The following is a description of a gene set: from publication Chen Y, Wang X (PMID 31504780) Genes predicted to be targets of miRBase v22 microRNA hsa-miR-6762-3p in miRDB v6.0 with MirTarget v4 prediction scores > 80 (high confidence targets). Human Gene Set: MIR6762_3P species: Homo sapiens, and this is the list of marker genes: ZNF652, WDFY3, SLC26A1, HSF5, TEK, OR2H1, SCN8A, INKA2, SMARCA5, COLGALT1, GNAO1, FSD1L, APBA2, CUEDC1, SMURF1, IFIT2, CDIP1, TGM4, STC2, ELOF1, ZNF250, CKAP2L, PPDPF, PLCE1, SLC25A25 (NCBI Gene Id 114789), ATP8A2, GRID2, SS18, FAM149B1, SORL1, FAM117A, ZNF609, TMEM214, FAM107A, IGF2, GGPS1, KPNA1, COL18A1, EXOC5, AWAT2, CNOT2, CAMK2G, STX16, IGSF10, AGO1, POGZ, MTF1, PCGF6, ARID1A, PNPO (pyridoxamine 5'-phosphate oxidase), SLC4A8, TRABD2B, IL1RAP, SMG6, TPRG1L, CHMP1B, PHC3, ZNF746, SCARA3, UBE2Q2, CPEB2, PALM2AKAP2, SCN2B, WASF2, SEC14L1, ZNF75A, ZFAND3, RFX2, L1CAM, APBA1, ABCC1, GPN1, KMT2D, OGFR, TBC1D16, CUL1, PHF24, N4BP2L1, PDE7A, KLHL25, GDAP2, LHFPL2, C16orf82, PRRX1, TECRL, BEND4, SYVN1, FAM91A1, ARHGEF15, MSANTD4, STIMATE, DESI1, AMER1, HAAO, ZNF333, CRTC1, COMMD9, CAPRIN2, ICOS, PRKG1, NFATC2, SNED1, MAPK7, EIF2S1, BEND6, CDK1, ELMO3, ARFGAP1, PPP1R14D, HSPD1, DENND2C, CDK19, MYBL1 (NCBI Gene Id 649850), PTTG1IP (NCBI Gene Id 756), HECTD2, ROR2, CADM3, ZBTB37, INSYN2A, MTCL2 (microtubule crosslinking factor 2), FBXW8, ALCAM, AFF4, NFIX